The following is a description of a gene set: Mouse Gene Set: DESCARTES_ORGANOGENESIS_OSTEOBLASTS Mouse Organogenesis Cell Atlas (MOCA) DE_gene_main_cluster.csv, fold.change>=1.5, qval<0.05, pval<0.05 from publication Cao J, Spielmann M, Qiu X, Huang X, Ibrahim DM, Hill AJ, Zhang F, Mundlos S, Christiansen L, Steemers FJ, Trapnell C, Shendure J (PMID 30787437) studied in species Mus musculus, and this is the list of marker genes: Pdlim2, Slc9a2, Mir6240, Il31ra, Panx3, Susd5, Cib2 (calcium and integrin binding family member 2), Tmub1, Tnks1bp1, Tmsb10, S100a11, Zfp960, Cstb, Camk1d, Susd2, 4933406J10Rik, Zfp72, Ibsp, Spon2, 1700102P08Rik, mt-Nd6, Ahnak, Dhrs1, Mea1